The following is a description of a gene set: from publication Cheok MH, Yang W, Pui CH, Downing JR, Cheng C, Naeve CW, Relling MV, Evans WE (PMID 12704389) To elucidate the genomics of cellular responses to cancer treatment, we analyzed the expression of over 9,600 human genes in acute lymphoblastic leukemia cells before and after in vivo treatment with methotrexate and mercaptopurine given alone or in combination. Based on changes in gene expression, we identified genes that accurately discriminated among the four treatments. Discriminating genes included those involved in apoptosis, mismatch repair, cell cycle control and stress response. Only 14% of genes that changed when these medications were given as single agents also changed when they were given together. These data indicate that lymphoid leukemia cells of different molecular subtypes share common pathways of genomic response to the same treatment, that changes in gene expression are treatment-specific and that gene expression can illuminate differences in cellular response to drug combinations versus single agents. Human Gene Set: CHEOK_RESPONSE_TO_HD_MTX_UP species: Homo sapiens Genes specifically up-regulated in pediatric acute lymphoblastic leukemia (ALL) patients by high-dose methotrexate (HDMTX)., and this is the list of marker genes: DEFA4, ABLIM1, FLNA, OLFM4, SLC1A4, S100A8, S100A9, S100A4, IL32, IGHA1, ARL4C (ADP ribosylation factor like GTPase 4C), ANXA2, AZU1, DEFA1, MYLK, BAX (NCBI Gene Id 581), CTSG, TRBC1, MPO, NFKB2, LYZ, ATM, TYROBP